Given this list of marker genes Ppat, Gart (NCBI Gene Id 14450), Impdh2, Paics, Adsl, Adss1, Impdh1, Pfas, Gmps, Adss2, Atic, here is a description of the gene set: studied in species Mus musculus Purine ribonucleoside monophosphate biosynthesis Mouse Gene Set: REACTOME_PURINE_RIBONUCLEOSIDE_MONOPHOSPHATE_BIOSYNTHESIS